The following is a description of a gene set: species: Homo sapiens A type of anemia characterized by increased size of erythrocytes with increased mean corpuscular volume (MCV) and increased mean corpuscular hemoglobin (MCH). Macrocytic anemia Human Gene Set: HP_MACROCYTIC_ANEMIA, and this is the list of marker genes: GATA1, PSMC1, RMRP, RPL11, RPS29, CUBN, TINF2, RHD, AMN, RPL31, SLC4A1 (NCBI Gene Id 8158), SLC19A1, MTR, RPS28, RPS27, RPL26, ALAS2, HLA-DQA1, SFXN4, RPL8, ADA2, RPL27, UMPS, HPRT1, RPS14, CDAN1, RPS24, RPL9, SLC19A2, RPS17, RPL18, RAC2, EFL1, MMACHC, LARS1, MTHFD1, OPA1, COX10, SLC30A7, LMBRD1, RPL35, DNM1L, RPS20, SLC46A1, RPS26, MMADHC, DHFR, TPI1, HLA-DQB1, RPL15, WFS1 (NCBI Gene Id 94141), RPS19 (ribosomal protein S19), SBDS, RPL35A, PHGDH, RACGAP1, DNAJC21, RPS7, KIF23, FTCD, RPS10 (NCBI Gene Id 6204), TCN2, RHCE, TSR2, RHAG, TET2, MTRR, KCNN4, RPL5, HEATR3, RPS15A, PIEZO1 (piezo type mechanosensitive ion channel component 1 (Er blood group)), UBA1, CBLIF, PRDX1